Given this list of marker genes ATP1B3 (NCBI Gene Id 483), GALR2, LRRC52, ATP1B1, KCNIP2, ABCC8, KCNQ1, KCNH2, KCNE5, KCNC1, DRD1, ANO6, ADRA2A, AKAP7, EDN3, LRRC55, ADORA1, KCNC2, TREM2, ANK2, ATP1B2, KIF5B (kinesin family member 5B), KCNE1, DLG1, AMIGO1, STK39, NPPA, LRRC38, FLNA, LRRC26, FHL1, AKAP6, KCNN4, GAL, OPRK1, MIR21, ACTN2, KCNJ2, NOS1AP, here is a description of the gene set: Any process that activates or increases the frequency, rate or extent of the directed movement of potassium ions (K+) into, out of or within a cell, or between cells, by means of some agent such as a transporter or pore. Human Gene Set: GOBP_POSITIVE_REGULATION_OF_POTASSIUM_ION_TRANSPORT species: Homo sapiens